Given this list of marker genes Trp53, Cct4, Pml, Map3k4, Zscan4c, Nat10, Nhp2, Gch1, Atr, Naf1, Wrap53, Prkcq, Mapk3, Nek7, Hnrnpc, Pnkp, Aurkb, Pot1b, Tert, Mapkapk5, Ercc4, Pif1, Terf2ip, Atm, Map2k7, Rad51 (RAD51 recombinase), Src, Hnrnpa2b1, Hnrnpu, Terc, Parp1, Dclre1b, Pinx1, Tnks2, Fbxo4, Pot1a, Cct8, Gnl3l, Ctc1, Rad50, Ptges3, Hnrnpd (heterogeneous nuclear ribonucleoprotein D), Rpa1, Stn1, Mapk1, Zscan4d, Pkib, Cct3, Ten1, Nop10, Terf1, Dhx36, Hsp90ab1, Xrcc5, Cct7, Tent4b, Cct6a, Cct5, Exosc10, Ctnnb1, Tnks, Tinf2, Gar1, Hmbox1, Dkc1, Tcp1, Parn, Dcp2, Wnt3a, Mapk15, Hsp90aa1, Zscan4f, Ptges3-ps, Rtel1, Terf2, Acd, Slx4, Zbtb48, Nek2, Tep1, Parp4, Mcrs1, Cct2, here is a description of the gene set: studied in species Mus musculus Any process that contributes to the maintenance of proper telomeric length and structure by affecting and monitoring the activity of telomeric proteins and lengthening the telomeric DNA. Mouse Gene Set: GOBP_TELOMERE_MAINTENANCE_VIA_TELOMERE_LENGTHENING